Given this list of marker genes TUT7, UAP1L1, TUT4, UAP1, UGP2, GALT, TUT1, here is a description of the gene set: Catalysis of the transfer of an uridylyl group to an acceptor. Human Gene Set: GOMF_URIDYLYLTRANSFERASE_ACTIVITY species: Homo sapiens